The following is a description of a gene set: studied in species Homo sapiens Gene expression profiles of subsets of CD4+ T cells according to their expression of FoxP3 and CD45RA were compared. FoxP3 is a key transcription factor for the development and function of natural CD4+ regulatory T cells (Tregs). Here we show that human FoxP3+CD4+ T cells are composed of three phenotypically and functionally distinct subpopulations: CD45RA+FoxP3low resting Tregs (rTregs) and CD45RA-FoxP3high activated Tregs (aTregs), both of which are suppressive in vitro, and cytokine-secreting CD45RA-FoxP3low non-suppressive T cells. The proportion of the three subpopulations characteristically altered in cord blood, aged individuals, and patients with immunological diseases. Terminally differentiated aTregs rapidly die while rTregs proliferate and convert into aTregs in vitro and in vivo as shown by the transfer of rTregs into NOD-scid-common gamma-chain-knockout mice and by TCR sequence-based T cell clonotype tracing in peripheral blood of normal individuals. Taken together, the dissection of FoxP3+ cells into subsets enables one to analyze Treg differentiation dynamics and interactions in normal and disease states, and to control immune responses through manipulating particular FoxP3+ subpopulations. from publication Miyara M, Yoshioka Y, Kitoh A, Shima T, Wing K, Niwa A, Parizot C, Taflin C, Heike T, Valeyre D, Mathian A, Nakahata T, Yamaguchi T, Nomura T, Ono M, Amoura Z, Gorochov G, Sakaguchi S (PMID 19464196) Human Gene Set: GSE15659_NAIVE_CD4_TCELL_VS_ACTIVATED_TREG_DN Genes down-regulated in comparison of naive CD4 T cells versus activated regulatory T cell (Treg)., and this is the list of marker genes: TLCD1, ZNF394, RUSC1, SAP30BP, RNF113A, VAMP3, STK25, TMEM125, SCGB3A2, SNORA65, ZAN, WDHD1, UBE4B, SLC4A9, TINF2, TMBIM1, SEMA6A, RSPH1, RNF167, SNED1, ZNF277, ZPBP2, EMC4, TRAK1, RHOH, SOX2-OT, UTS2B, TMEM158, TTC7A, SCN8A, SLC44A3, RENBP, TFF2, PRDM1, STING1, TRIM16, SRL, ARHGAP42, ZSCAN29, RTP1, RANGRF, PSMA2, PRKAG3, SLC22A1, SF3B4, TP53INP2, RAB8B, TOMM22, TSNAX, TNF, SHISA6, UGT2B17, TRAPPC6B, PYHIN1, TOR1AIP1, RSPH10B2, RNF10, SLC41A1, SPATC1, ROS1, SNX3, TRPM6, SH2D1A, SARS2, RD3, PPP2R1A, STARD4, ZMIZ2, TIMM17A, TK1, PSRC1, PRDX4, UBE2U, ZNF324B, ROPN1B, SLC16A11, PPP4R2, ST7-AS1, TPI1, TPSAB1, S1PR2, PVR, ZNF28, SPATA12, UBE2J1, SEPHS2, ZCCHC13, RBM28, SHB, RAB2B, PSEN1, THRB, U2AF1, WARS1, TTC33, DNAAF10, SYN2, ZBED6, SEC24D, SLC43A3, TLR4, TMEM208, SLC22A18 (NCBI Gene Id 8042), TDRD7, PTPN18, STK32A, SLC39A1, SLC39A7, RNF214, PRG3, TBCCD1, TAS2R9, SSR2, LINC01121, RBPMS, TP63, LINC00310, RRM1, THBS2, TBX3, ZNF557, RASD1, REM2, TMCO5A, SEC23B, TP53I13, SCARF2, RANBP9, TPMT, PSMA6, RNF19A, ZNF414, AFG2B, SLC25A2, RGS4, USP43, RAMP1, POLR1H, GFUS, SPDYA, PPM1K, PXDNL, RHBDL2, ZIC1, SLC45A1, ZFP36L1, TOP3A, SLC4A2, ZNF596, PTH2R, ZFAND5, SLFNL1, S100A16, RGS17, TBC1D4 (NCBI Gene Id 9882), ZNF142, NECTIN4, DENND2B, SLC35F3, SEPTIN3, PSMG2, SCO2, UBL3, SLC9A5, SNAP91, ROCK1, RHOC, SGO2, SCEL, SHMT2, SAGE1, TTL, DESI2, RTP3, SNAI2, TCP10L3, SEMA4A, RPE65, PPP2R5A, PRRG3, SLC6A7, STK16, SEMA7A, ZC3H13, TRIML1, PRAMEF12, UBL7, RAP2B, SNRNP40, TMEM126A, RPL26L1, GET1, SLC9A8, SPATS2L, ZNF34, ZNF861P, SOX11, TRIP12